The following is a description of a gene set: Human Gene Set: KEGG_MEDICUS_PATHOGEN_HCV_CORE_TO_RXRA_PPARA_MEDIATED_TRANSCRIPTION studied in species Homo sapiens Pathway Definition from KEGG: Core -> (RXRA+PPARA) => (CCND1,CDK4,MYC) HCV core to RXRA/PPARA-mediated transcription. Pathway ID: N00529. Pathway type: Pathogen. Pathway class: nt06263 Hepatocellular carcinoma., and this is the list of marker genes: RXRA, PPARA, CCND1 (cyclin D1), MYC, CDK4